The following is a description of a gene set: Human Gene Set: HP_ADRENAL_INSUFFICIENCY species: Homo sapiens Insufficient production of steroid hormones (primarily cortisol) by the adrenal glands. Adrenal insufficiency, and this is the list of marker genes: OCA2, PEX1 (NCBI Gene Id 7788), PEX14, PEX19, GPR101, PWRN1, NFKB2, HSD17B4, SAMD9, RBM28, GLI3, LHX4, MEN1, GMPPA, PWAR1, PEX11B, SNRPN (NCBI Gene Id 6638), PEX26, MAP3K1, VAMP7, HSD3B2, ABCD1, AIP, STEAP3, PEX2, CYP11A1, PEX5 (peroxisomal biogenesis factor 5), LIPA, TXNRD2, PROP1, MC2R, KANSL1, ZFPM2, MAGEL2, MCM4, WT1, CYP17A1, CTNNB1, SRY, SNORD116-1 (NCBI Gene Id 100033413), PCSK1 (NCBI Gene Id 5122), BCOR, PEX6 (NCBI Gene Id 5190), NDN, PEX3, TRAPPC11, PEX16, PEX12, GATA4, HBB, MKRN3, TBX19, IARS2, TBCK, NNT, POMC, PEX13, TCTN3 (NCBI Gene Id 26123), WWOX, CDH23, MRPS25, AAAS, BRAF, NFS1, SAA1, POR, SGPL1 (NCBI Gene Id 8879), GK, MRAP, DHX37, NDUFAF5, PEX10, AIRE, SOX9, NR0B1, SNORD115-1, NPAP1, NR5A1, HERC2, STAR, MRPS7